Given this list of marker genes DLL4, HDAC9, TBL1XR1, HDAC4, MIB2, DLL1, JAG1, NCOR1, HEYL, HES1, CDK8, NEURL1, NCOR2, EP300, RBX1, HDAC10, NCSTN, MAML3, ADAM10, PSEN2, HDAC8, APH1B (NCBI Gene Id 83464), HDAC2, HEY1, HDAC3, FBXW7, MAML2, SNW1, UBC, HDAC1, RPS27A, PSENEN, HEY2, JAG2, UBB, NOTCH1, CUL1 (cullin 1), PSEN1, TBL1X, HDAC7, HDAC5, MIB1, KAT2B, APH1A, HES5, MAMLD1, MYC, RBPJ, CREBBP, CCNC, KAT2A, HDAC11, HDAC6, UBA52, SKP1, NEURL1B, MAML1, ADAM17 (ADAM metallopeptidase domain 17), here is a description of the gene set: studied in species Homo sapiens Signaling by NOTCH1 PEST Domain Mutants in Cancer Human Gene Set: REACTOME_SIGNALING_BY_NOTCH1_PEST_DOMAIN_MUTANTS_IN_CANCER